The following is a description of a gene set: from publication Busslinger GA, Weusten BLA, Bogte A, Begthel H, Brosens LAA, Clevers H (PMID 33691112) species: Homo sapiens Human Gene Set: BUSSLINGER_GASTRIC_IMMUNE_CELLS, and this is the list of marker genes: PLEKHO2, CBL, C19orf12, KAT2B (NCBI Gene Id 8850), PPP2R5E, KLRC1, SLC2A3, MYO1F, FLT3LG, RPA1, SMAD7, PACS1, RPL6, SELPLG, ITSN2, AZIN1, HLA-A, SENP7, CD2, RACK1, YME1L1, PSMB4, CD48, CTSW, RIGI, NEDD9, JADE2, KIAA0040, JUNB, CYTIP (NCBI Gene Id 9595), ZBTB4, EIF4G2, SEL1L3, RAB8B, PRKD2, TIGIT, RHEB, SMARCE1, H3-3B, DAXX, THAP12, TMEM109, RPL17, FHOD1, CHASERR, MAP1LC3B, TTC14, RNF4, FLNA, AKNA, AKAP13, PSMB9, YWHAQ (NCBI Gene Id 10971), TNFSF14, NCOR1, VPS26A, ANKRD44, TBC1D10C, CTCF, COTL1, CD47, S100A4, RPS27, IDI1, STAT5A, UBASH3A, TASOR, BTN3A2, CENPC (centromere protein C), RPS11, DRAP1 (NCBI Gene Id 119810), PTPN4, ZNF644, SRSF5, MEAF6, CYLD, TMED5, TBCB, ZBTB1, HERC1 (NCBI Gene Id 8925), CSGALNACT2, NOTCH2, ALOX5AP, MATR3, SLF1, WAPL, HLA-C, TACC1, THEMIS, PRKAR1A, IER5, TDP2, OAZ1, JAK1, PPP1R15A, TIAL1, OXNAD1, BIRC6, PSIP1, MOB3A, P2RX5, DEF6 (NCBI Gene Id 50619), CDC42EP3, ZNF721, MATK, CUL3, ODC1, PSD4, GMIP (NCBI Gene Id 51291), DNAJB6, PAG1, GRK6, MECP2, KDM5A (NCBI Gene Id 5927), PHF3, ARHGAP30, RPS16 (ribosomal protein S16), DOCK11, SMURF2, OSTM1, TNFRSF1B, TTN, GNAI3, LYSMD2, ARID5A, MGAT1, RPS19, ESYT1, ZNF831, ADA2, XRN2, HNRNPH3, UBASH3B, TNRC6B, CSK, PLCG1, FYN, TYW3, PTPN22, RGS2, DAZAP2, CRTAM, XPO4, AP1S2, PRPF38B, ADARB1, NEMF, SPTAN1, TRANK1, CREBBP, ATM (NCBI Gene Id 8068), MIS18BP1, UBE2D2, ST3GAL1, NUP98, CD5, CALM3, PTPRE, ITK, CD81, MYCBP2, PSMA3-AS1, BLTP1, PIEZO1, TERF2IP, CD52 (NCBI Gene Id 1043), ADGRE5, ATXN7, CRYBG1, ST3GAL5, HMGN4, RGS14, CGGBP1, STK10, CD3D, SAMSN1, APMAP, POU2F2, IL17RA, AP4B1, SF1, CD4, TGFB1, THRAP3, URI1, TRIM38, NFAT5, CDKN1B, LTB, FGFR1OP2, PLAAT4, KPNA4, PSME2, SAMD9L, CXCR3, SLA2, NAA38, AIDA, LAPTM5, STN1, TMEM131L, ELF1, CARINH, MAT2B, ABHD3, ATXN1, CFL1, IFNAR2, FAM89B, LINC00426, ARHGEF3, ITPKB, DDX3Y, NUFIP2, ICAM3, RBM27, PIK3R1, LDLRAD4, TUT4, GLS, RALGDS, CITED2, MAP3K2, WIPF1, CRLF3, SNTB2, DENND4A, NHERF1, TSPAN32, FLI1, ARHGEF1, SFMBT2, TLN1, MTR, CCNT2, RPS12, SLA, CD244, OFD1, FCRL6, PTK2B, SLFN11, HIVEP3, SASH3, SPN, PRP4K, PPP2R5C, PSMB8, ERAP1, PDE4B, SIGIRR (single Ig and TIR domain containing), BTBD1, GNAS, PAFAH1B1, BMAL1, TAPBP, SCAF8, SRGN, GLO1, PCBP1, USP42 (NCBI Gene Id 84132), ARPC3, TBK1, GRB2, METTL9, ZBTB44, ATP8B2 (ATPase phospholipid transporting 8B2), MTMR9, WWC3, PRPF8, RHOH, CCR2, GPR155, FOXN2, APOBEC3F, EPC1, GOLGA7, HLA-F, MTDH, BAZ1A, TOR1A, CASP1, SNX3, RGS16, DIP2A, LDHA (lactate dehydrogenase A), SESN3, RPS23, CD84, MYLIP, DOCK9, BIN2, RPL7A, APBB1IP, RPL10A, GRAMD1A, TAF7, XPO1, TBCC, TRAF3IP3, RAB29, SOS1, RPL9, PDCD1, RAP1B, YBX1, RPS20, STAT4, FCER1G, RAB21, CXCR6, SF3B1, ZAP70, CBFB, PCM1, PVRIG, PPP4R3A, AHNAK, TMSB10, EIF4EBP2, RANBP2, XRCC6, ATP5MG, TGOLN2, LPIN2, SIPA1, TRAM1, TPP1, STK17B, TRAF5, SAMD3, HTR7, IFITM1, NEK9, CYTH4, LAX1, TRPS1, PARP1, SEPTIN1, GGA2, MYL12B, FAS, HLA-DPB1, CD27, DEGS1, TMEM123, CD3E, LINC00857, RFX7, SELENOT, IKZF1, EML3, ARHGAP25, HIPK1, SYNE1, ARID1A, COMMD6, KANSL1, DICER1, CYBC1, RSF1, KDM2A, IL10RA, SH3BP1, CBLB, SMAP2, RNF19A, ANAPC16, BCL2, ARPC1B, RFTN1, CDC42, LRRN3, USP15, LRBA, TXNIP, IFITM2, STK24, OTUD4, GIMAP2, XPO6, MVB12B, CKLF, PPT1, RPS3, FYTTD1, RPS27A, PARVG, TPT1, FAM53B, VAV3, SLC2A4RG, SETD2, SMC3, EPS15, SLFN5, SMG1, GPCPD1, PRPF40A, TRIM22, PARP14, CHD2, IFI27L2, CBX7, MIAT, TBC1D1, BZW1, GYPC, PAIP2, U2SURP, VIM, MXRA7 (NCBI Gene Id 54588), MBNL1, PSMB8-AS1, RETREG1, MPHOSPH8, ARHGAP4, LATS1, PHC3, TPR, SYNRG, ABHD17A (abhydrolase domain containing 17A, depalmitoylase), DCP2, FMR1, PGGHG, TLK1, ZFP36, DUSP6, RBM26, RAC2 (NCBI Gene Id 5880), IL16, XRN1, RBM12, KLHL28, GPR183, METTL23, TAOK1, MAN1A2, RPLP1, TGFBR2, ZBTB38, MICB, USP9X, PPP1R16B, DR1 (NCBI Gene Id 1810), IPCEF1, ASH1L, MED1, TBC1D2B, GZMH, CDC42SE2, CD7, CCL4, AP3M1, NR4A2, PTGER4, PIP4K2A, RAD21, RPS29, RPL34, HOPX, FOXJ3, GRK2, SIT1, TARP, USP20, TMSB4X, ERBIN, S100A10, SP140, ARPC2, NMRK1, CCL5, PAPOLG, SERTAD2, RASAL3, FUS, SNHG5, SSB, TNRC6C, YWHAZ, MAPRE1, NABP1, ASCC3, ZNF638, EVI2A, PLXDC1, ANKRD49, KBTBD2, YTHDC2, APOBEC3G, NSMAF, RAPGEF6, RPL41, UBA52, GBP3, WDR82, TOR1AIP1, ARHGAP15, APBA2, ASF1A, NIN, RASSF2, IL18R1, AOAH, TOX, STYX, UBR5, WNK1, ARL6IP5, SCAF11, ZYX, CASP8 (NCBI Gene Id 841), TTC39C, ABI3, HIC1, DSTYK, WAS (WASP actin nucleation promoting factor), RPA2, STK4, RPL37, RESF1, ZNF148, MAN1C1, RPL31, DEK, ZC3H6, LSM14A, ARPC5, SBNO2, BTN3A1, IDS, ICE1, ITGB2, ATP1B3, TNK2, PTPN7, PLCB2, ELP1, AP1M1, CLK1, SET, TOP2B, HMGB1, MCL1, MAP4K1, UHMK1 (U2AF homology motif kinase 1), PDE4DIP (NCBI Gene Id 9659), CTLA4, MYH9, SEPTIN7, RPL35A, ABI1, RPL39, LEPROTL1, CD53, CD8B, SLC4A7, APOBEC3C, KLRB1, RBM39, HLA-H, JADE1, GNG2, ANP32B (NCBI Gene Id 138551, acidic nuclear phosphoprotein 32 family member B), HLA-DPA1, TLE5, ZNFX1, NFATC2, RSRC2, ANXA1, WAC, MFNG, PHF20L1, LAIR1, PRNP, PNISR, SH3KBP1, BATF, NOP53, N4BP2L2, USP25, YPEL3, FNTA, ANTXR2, BUB3, SP110, POLR2B, EFR3A, PPIG, UBXN4, ATR, PNRC1, NOTCH1, SACM1L, TRMT112, ENO1, IRF1, RBM38, CCNH, GLCCI1, MYBL1, KCNAB2, LCP1, SSH1, KLF13, TBC1D4 (TBC1 domain family member 4), APOBR, SRSF2, PAXX, ATP6AP2, SPATA13, AGGF1 (NCBI Gene Id 55109), OGT, RHOA, SHISA5, BST2, ATF2, UBR2, INTS6L, STAT3, ZBED5, CCSER2, RPL30, KAT6A, ANKRD28, SIK3, TMEM43, JUND, CNTRL, CDC16, CORO1A, JARID2, TMC8 (NCBI Gene Id 147138), SKAP1, MACF1, AKIRIN1, VOPP1, NIPBL, GPATCH8, PTPN11, RBBP6, ZNRF1, IL2RG, EIF1, STIM2, RPL19, PDCD4, RNF216, LPXN (NCBI Gene Id 9404), XCL2, TPSAB1, GPR65, SLAIN2, ETS1, GIMAP4, TSPYL2, ATOSA, TBCD, RUNX2, PRDM2, TESPA1, PLEKHO1, NAP1L1 (NCBI Gene Id 64165), PTPN6, CEP350, TRIP12, BHLHE40, DENND1C, VWA5A, MAP7D3, PIK3R5, LDHB, PTPRCAP, TYROBP, RGS10, RPL23, EIF4B, RPS3A, PPP4R3B, LCP2, RPS4X, DZIP3, GMFG, ADCY7, ATP8A1, IL17A, PPP1R12A, FGD3, AHR, CELF1, KTN1, RNF125, SRGAP3, LY9, TRPV2, PUM2, STAT1, EEF1A1, HSPA8, GSTK1, FASLG (NCBI Gene Id 356), PTMA, TRAPPC10, ZEB2, WDR1, DNMT1, AGFG1, VPS13C, LINC-PINT (long intergenic non-protein coding RNA, p53 induced transcript), LASP1, PAK2, TINF2, GIT2, CACYBP, HLA-B, ITGAE, YTHDC1, SNHG1, PNN, NPM1, KLF12, FAM78A, NONO, FBXL20, ITM2B, CPA3, TSC22D3, MAP2K1, GIMAP1, PCGF5, RPL23A, ZFP36L2, JAK3, IL27RA, UBLCP1, NSD1, ADAR, QKI, KIDINS220, TSEN54, PCED1B, TRIB2, NLRP1, CSNK1G2, TRIM33, BRWD1, RPS13, MYO5A, RNF139, CSF1, TSPAN14, ESYT2, CLIP1, RPL36AL, SPG11, STIM1, ARHGAP9, INPP4B, ATF7IP, CHSY1, CCL20, MLLT6, MYO7A, SETX, DPP8, KIT, LRRFIP1, OTUD5, PLP2, CLSTN3, PRKACB, RPS6KA3, NLRC5, PICALM, JCHAIN, NUP153, SUSD3, NUP210, BTF3 (NCBI Gene Id 689), IL2RB, SUB1, SMC5, OST4, LAG3, EEF1D, IFNG, RNF114, PCNP, HINT1, CSDE1, PITPNC1, USP34, RAP1GDS1, STT3B, DARS1, SUN2, RALGAPB, HMGN1, PPM1K, CRBN, CD3G, VEZF1, FYB1, CERK, IGFLR1, FLOT2, CIDEB, ZFYVE28, H2AZ2, EIF4E3 (NCBI Gene Id 317649), STAG2, NPAT, ATP6V0E2, AIP, PTGES3, ELOVL5, CXCR4, FERMT3, PFDN5, SLC26A2, TRA2B, GATA3, EMB, PRKCQ-AS1, TAGAP, SLC5A3, NXPE3, SLC66A3, HLA-E, HERPUD2, NDST2, C9orf78, SEPTIN9, DGKE, RASGRP2, ITM2A, CLEC2D, SHFL, COPB1 (NCBI Gene Id 51664), PPIA, ADAM8, CCDC88A, GFOD1, SERPINB9, RAP1A, ZDHHC18, SNRNP200, CAPZB, RPL27A, PDLIM2, HNRNPA3, ANKRD10, SLC18A2, PHF19, HNRNPDL, ATP11B, HCP5, IKZF3, ACTR2, CNOT1, PELO, MCMBP, C4orf3, DERL1 (derlin 1), MRFAP1L1, VPS11, EPG5, ZNF609, PBXIP1, ANKLE2, PSMA7, FXYD5, F2R, OSTF1, DNAJB14, KMT2A (NCBI Gene Id 79951), CHST11, VSIR, SLC38A1, GBP5, MGAT4A (NCBI Gene Id 11320), LGALS1, SLAMF1, SLK, MAN1A1, DOK2, CALCOCO2, PDE7A, GLIPR2, SRPRA, ARIH1, GAPVD1, TSPAN5 (tetraspanin 5), UTRN, GBP2, TAB2, HECA, EEF1B2, MYO1G, ZNF683, ARRB2, PDS5B, BAZ1B, SYTL3, DOCK8, ARID4B, LCK, AKAP9, SEPTIN6, CAPN2, CCNI, IRAK4, ARF6, ACAP2, ISCU, PCNX2, TMA7, KMT2C, CNOT2, SLAMF7, ITM2C (NCBI Gene Id 9523), WDR26, KAT6B, IK, RFLNB, RORA, MIER1, ITGB1BP1, REV3L, MAN2A2, SPEN, PSTPIP1, BBX, PRKD3, DYRK1A, RHOG, CELF2, ACTR3, SETD5, MAF, BIRC3, CARD11, CYFIP2, CST7, CAP1, ATRX, MED13, MAPK1 (mitogen-activated protein kinase 1), CCR5, SH3BGRL3, RPL26, CDV3, PHLDA1, PTAR1, GIMAP6, DGKA, CREB1, SBNO1, GNB1, GNA13, TNF, AKAP10, NUMA1, ROCK1, ITPR2, KPNA6, EIF5, IL7R, ENSG00000284634, SH2D1A, ZC3H11A, ABCB1, PRMT2, DOCK10, POLR3GL (NCBI Gene Id 84265), SUZ12, SNRK, BPTF, TMEM35B, RBM33, ZNF217, DOCK2, ELK4, PDS5A, TPM3, ARHGAP45, ACTB, CARD8, CEP85L, DUSP2, TRG-AS1, PTPN1, CCT4, DMTF1, PRF1, ITGA4, SAMD9, NRDC, GZMA, MARCHF7, UBE3A, HOXB2, BDP1, STX16, CD69, TMF1, SF3A1, ELL, OSBPL8, SLAMF6, LNPEP, FNBP4, HNRNPLL, RPS2, PYHIN1, CCDC88C, HNRNPU, FBXO11, LUZP1, SARAF, XRCC5, NKG7 (NCBI Gene Id 4818), TOMM7, GGNBP2, FMNL3 (formin like 3), TRERF1, LY6E, MDFIC, PPHLN1, UBA2, ADD1, TRIM14, TUBA1A, USP1, TANK, XIAP, BICD2 (NCBI Gene Id 23299), SMCHD1, SON, SERINC1, TCF7, TRAF1, PCF11, SIGLEC17P, CCNDBP1, BTG1, MDM4, RGCC, SIRPG, SPCS3, INPP5D, FKBP11, PRKCQ, PHTF2, VAV1, CD6, RABGAP1L, RPL15, ZMAT3, PREX1, NLRC3, CLDND1 (claudin domain containing 1), HUWE1, GIMAP7, ARID4A, RALGAPA1, PPM1A, IFI44, ZC3HAV1, BOD1L1, EEF1G, DENND4B, SEMA4D, GABPA, ASAP1, GZMB, EVL, EHD1, TCP1 (t-complex 1), RPL4, MAP7D1, PPP1R15B, ICOS, NIBAN1 (NCBI Gene Id 63911), TUBA4A, ERAP2, IFFO1, SF3B3, DENND1B, LPIN1, KMT2E, RGS19, PAPOLA, UBE2L6, HECTD4, CMTM3, INO80D, ANKRD11, MYL12A, UBR1, PTGDR, ARHGEF6, SMARCA2, PPP3CC, CLEC2B, UBE2D3, RPS6KA5, KMT2D, HNRNPH1, ZNF800, PIK3IP1, STOM, SECISBP2, RNF149, ACAP1, SIN3A, PLEKHA2, BBLN, VPS13B, EIF4A2, BIN1 (bridging integrator 1), KPNB1, NAP1L4, FKBP5, ZNF276, GPSM3, MYO9B, RASSF5, DNTTIP2, MICAL1, MBD2, FAM13B, SLC7A6, RIF1, JAML, RASA1, NFKBIA, FHIP2A, RNF44, DUSP1 (dual specificity phosphatase 1), SORL1, KCMF1, DDX6, ITGA1, SLF2, PCNX1, PTBP3, FMNL1, SLC20A1, PRDM1, LBH, STK17A, RO60, MEF2D, MXD4, RPL38, CYRIB, CD101, PTPRJ, MSN, RPL13, RPL32, EP400, NGLY1, ATP2B4, TAOK3, GPR171, CCND2, SMARCA5, HIVEP2, C12orf57, SSH2, PSMB10, OAS2, FOSB, MYSM1, SH2D3C, UBE2I, PIM2, STAT5B, EID1, DDX3X, PPM1M (NCBI Gene Id 132160), EIF3F, GZMM, BCL11B, YPEL5, TUBB, MRPS6, RNF166, KRI1, JMY, RICTOR, USF2, RPL24, DHX9, CCNL1, PTPN2, NCKAP1L, GAB3, C21orf91, B2M, TBRG1, HCLS1, ASXL2, ARHGAP35, ACSL4, ID2, RPL14, DYNC1H1, TC2N, UNC13D (unc-13 homolog D), KLRC2, EMP3, BRD10, KLRD1, G3BP2, PPP1CC, ARAP2, RPL27, RUNX3, TNFRSF25, BTAF1 (B-TFIID TATA-box binding protein associated factor 1), LONP2, ADAM19, ELMO2, FBXW2, ZEB1, CHST12, BCLAF1, CREBRF, SKI, OGG1, DDIT4, RGS1, RB1CC1, RBMS1, MAPK1IP1L, LINC02591, IVNS1ABP, SH2D2A, RPL13A, ATXN2L, PRRC2B, RAPGEF1, AAK1, CCDC88B, PLEKHF1, UGP2, FCMR, C16orf54, C6orf62 (NCBI Gene Id 81688), ZNF292, CAPZA1, ZFC3H1, GZMK, VMA21, PPP2R2B, RCSD1, RNF213, MAST3, SENP6, SLC2A1, VAMP1, TMEM50A, PSME1, PIK3CD, OGA, GAPDH, GFI1, MR1, IQGAP1 (IQ motif containing GTPase activating protein 1), NFATC3, PHF11, GPBP1, PARP8, RANBP9, CCR6, PTPRC, GYG1, CAB39, YWHAB, ZFP36L1, ANP32E, PRKY, CDC14A, RPL5, IFI16, COMMD8, RAB27A, TAP2, ARHGDIB (NCBI Gene Id 397), SSBP4, RFX5, FOXO1, JMJD1C (jumonji domain containing 1C), SH3BGRL, CD44 (CD44 molecule (IN blood group)), TNFAIP3, RPS15, RIPOR2, RBPJ, KIF21B, INPP4A, EP300, TGFBR1, ITPR1, CHD1, RASA2, DCP1A, GATA2, CNBP (NCBI Gene Id 7555), NCOA1, MAPRE2, SPOCK2, CD247, PHIP, TMC6, ANXA6, FAU, ARID2, TBL1XR1, KLC1, PPP1R18, PPP6R1, RPL7, SUSD6, LANCL1, AKAP11, HCST, LBR, GNPTAB, PTP4A2, RNF38, RPL37A, HELZ, UBC, EVI2B, CXCL13, CREM, GNLY, DDX17, CYBA, MS4A2, PHF20, IL18RAP, CDK13, SH2B3 (NCBI Gene Id 10019), GATAD2B, RBL2, SLC16A7, ASB2, DCAF5 (NCBI Gene Id 8816), SELENOF, FNBP1, USP24, CNN2, NR3C1, UCP2, DENND2D, DUSP4, ATP6V0E1 (NCBI Gene Id 8992), RPS18, TPSB2, CDK17, RPS14, FRYL, FAM111A, RPS25, CHD3, SPEF2, CLIC5, SRSF10, MARK3, CNOT6L, PRKCH, CBX3, SURF4, EEIG1, RAB3GAP2, UBR4, RPS15A, RPL10, TNFSF12, CYTH1, SACS, FBXL3, ZNF652, DYRK2, GDI1, GNAI2, CD8A, HEG1, CCDC85B, RNF167, ARPP19, PPP3CB, TGFBR3, SCML4, PECAM1, TRAPPC8, EIF3H, STMN3, PIM1, DIAPH1, PPM1B, KLF6, FBRS, ZNF655, RASGRP1, BIRC2, MFSD10, RPS7, MBP, LIMS1, SNHG6, ZFAND5, TWF2, GLIPR1, PGK1, MARCHF6, SRSF7, USP47, RPLP2, AUTS2, DHRS7, NFATC2IP, SP3, LINC00674, ITGAL, EDEM1, PIKFYVE, DDX5, KIF2A, GVINP1, DDX24, ZFR, SLC7A5P2, REST, CD96, NBEAL2, PRKCB, ST8SIA4, EML4, AKTIP, GPRIN3 (NCBI Gene Id 285513), ARL4C, STING1, CKAP2, CTBP1 (NCBI Gene Id 1487), KHDRBS1, TSC22D4, SEPTIN2, GRAP2, ITGB7, NCOA3, CD37, HAUS6, LIMD2, LPGAT1, IL32, LAT, N4BP1, CCND3, PARP9, GLG1, TBC1D20, NUDT21, PTPRA, CALM1, NEK7, PTGER2, CIAO1, ZMYM5, RPL28, MIR23AHG, BTG2, LYST, HNRNPA2B1, CISH, ABRACL, GIMAP8, CCDC69, PTDSS1, UBTF, CTSS, TNFAIP8, MALT1, PFN1, LSP1, TAP1